The following is a description of a gene set: species: Homo sapiens The resealing of a cell plasma membrane after cellular wounding due to, for instance, mechanical stress. Human Gene Set: GOBP_PLASMA_MEMBRANE_REPAIR, and this is the list of marker genes: MYOF, CAV3, MYH9, CHMP4B, CHMP1A, CHMP4A, RAB3A, VPS4B, S100A10, SMPD1, CHMP4BP1, SYT11, CHMP5, CHMP1B, CHMP4C, ARL8B, SYT7, CHMP3, CHMP2A, AHNAK, VPS4A, CASP7, SYTL4, ANO5 (NCBI Gene Id 203859), CHMP7, CHMP2B, MYH10, ANXA2, CHMP6, TRIM72